The following is a description of a gene set: Human Gene Set: chr14q21 species: Homo sapiens, and this is the list of marker genes: MGAT2, LRR1, SNORD127, SEC23A-AS1, PNN-AS1, KLHDC2, LINC01588, PNN, SSTR1, TUBBP3, MDGA2, ENSG00000259072, POLE2, ENSG00000251858, RN7SL3, FOXA1, FKBP3, FANCM, KRT8P1, COILP1, YTHDF2P1, RPA2P1, TTC6, LINC02307, LINC02315, RNU6-297P, PRPF39-DT, RRAGAP1-AS1, HNRNPUP1, MIR548Y, ENSG00000286595, PRPF39, LINC00871, RHOQP1, DMAC2L, RNU6-1277P, SOS2, LRFN5-DT, RNU6ATAC30P, CLEC14A, LRFN5, LINC00639, RRAGAP1, LINC02277, DNAAF2, GEMIN2, RNU6-539P, ENSG00000301174, RPL32P29, L2HGDH, RPL7AP2, RN7SL1, FSCB, FKBP1BP1, VCPKMT, MIA2, LINC00648, YWHAQP1, PPIAP4, RNU6-886P, DNAJC19P9, RPL36AL (ribosomal protein L36a like), C14orf28, MIS18BP1, RPL10L, MIA2-AS1, RN7SL2 (NCBI Gene Id 378706), EIF4BP1, RPS29, RNU6-189P, TOGARAM1, RPS15AP3, NEMF, KLHL28, LINC00517, LINC02303, PDLIM1P1, SNORD58, ARHGAP16P (NCBI Gene Id 319102), GLRX5P3, RN7SKP193, STK16P1, FBXO33, KRT8P2, MIR6076, ATP5MC2P2, KLHDC1, RPL13AP2, TRAPPC6B, ARF6, YWHAZP1, RNU6-552P, RNA5SP384, RPL18P1, SEC23A, DOCK11P1, MIR4504